Given this list of marker genes HPGD, STRA6, MYOCD, FOXF1, TFAP2B, here is a description of the gene set: The morphogenesis process in which the ductus arteriosus changes to no longer permit blood flow after birth. The ductus arteriosus is the shunt between the aorta and the pulmonary artery which allows blood to bypass the fetus' lungs. Human Gene Set: GOBP_DUCTUS_ARTERIOSUS_CLOSURE species: Homo sapiens